The following is a description of a gene set: Binding to double-stranded telomere-associated DNA. studied in species Mus musculus Mouse Gene Set: GOMF_DOUBLE_STRANDED_TELOMERIC_DNA_BINDING, and this is the list of marker genes: Terf2, Apex1, Zbtb48, Rad50, Pura, Purb, Hmbox1, Xrcc5, Xrcc6, Terf1